Given this list of marker genes DISC1, KIFC1, KIF5A, KLC2, BORCS5, KIF27, NDEL1, KIF9, KIF25, KIF3B, KIF1A, KIF21A, KIF1C, KIF3A, KIF21B, KIF16B, KIF5B, KIF19, KIFC2, KIF20A, KIF12, KIF2C, KIF11, KIF23, KIF6 (NCBI Gene Id 387085), KIF15, KIFC3, KIF18B, KIF17, KIF20B, KIF7, KIF22, KIF13B, KIF14, PAFAH1B1, NDE1, KIF2B, KIFAP3, KIF2A (kinesin family member 2A), KIF18A, KLC3, KIF13A, KIF28P, KIF3C, KIF5C, KLC4, KLC1, KIF1B, here is a description of the gene set: Any complex that includes a dimer of molecules from the kinesin superfamily, a group of related proteins that contain an extended region of predicted alpha-helical coiled coil in the main chain that likely produces dimerization. The native complexes of several kinesin family members have also been shown to contain additional peptides, often designated light chains as all of the noncatalytic subunits that are currently known are smaller than the chain that contains the motor unit. Kinesin complexes generally possess a force-generating enzymatic activity, or motor, which converts the free energy of the gamma phosphate bond of ATP into mechanical work. Human Gene Set: GOCC_KINESIN_COMPLEX studied in species Homo sapiens